Given this list of marker genes SGCE, HTRA2, SPART, CDKN2A, FH, PINK1, SDHC (NCBI Gene Id 6391), VHL, EPAS1, ATRX (ATRX chromatin remodeler), MAX, UCHL1, NR3C1, CIZ1, SDHB, DNMT3A, RET, KCNN2, CDKL5 (cyclin dependent kinase like 5), SYNJ1, EP300, SPECC1L, SNCA, KIF1B (kinesin family member 1B), TERT, PARK7, VPS13C, SLC25A11, CDH23, NF1, DRD2, TP53, LRRK2, USP48, CTNNB1, SDHD, TMEM127, TOR1A, USP8, PODXL, PRKAR1A, KCTD17, PRKN, ZNRF3, DNAJC6, DLST, SDHAF2, BRAF, MECP2, SMC1A, CREBBP, NTNG1, MDH2, GABBR2, SDHA, here is a description of the gene set: studied in species Homo sapiens Panic attack A sudden episode of intense fear in a situation where there is no danger or apparent cause. Human Gene Set: HP_PANIC_ATTACK